The following is a description of a gene set: Mouse Gene Set: LIANG_HEMATOPOIESIS_STEM_CELL_NUMBER_SMALL_VS_HUGE_UP We mapped quantitative trait loci that accounted for the variation in hematopoietic stem cell (HSC) numbers between young adult C57BL/6 (B6) and DBA/2 (D2) mice. In reciprocal chromosome 3 congenic mice, introgressed D2 alleles increased HSC numbers owing to enhanced proliferation and self-renewal and reduced apoptosis, whereas B6 alleles had the opposite effects. Using oligonucleotide arrays, real-time PCR and protein blots, we identified latexin (Lxn), a gene whose differential transcription and expression was associated with the allelic differences. Expression was inversely correlated with the number of HSCs; therefore, ectopic expression of Lxn using a retroviral vector decreased stem cell population size. We identified clusters of SNPs upstream of the Lxn transcriptional start site, at least two of which are associated with potential binding sites for transcription factors regulating stem cells. Thus, promoter polymorphisms between the B6 and D2 alleles may affect Lxn gene expression and consequently influence the population size of hematopoietic stem cells. from publication Liang Y, Jansen M, Aronow B, Geiger H, Van Zant G (PMID 17220891) Genes up-regulated in LSK cells (bone marrow) as a function of a QTL for the size of hematopoietic stem cell (HSC) population: comparison of congenic D.B. Chr 3 (DB, small HSC population) vs parental D2 strain (huge HSC population). species: Mus musculus, and this is the list of marker genes: Pls3, Lyrm2, Tlcd4, Gsta4, Tpm4, Mat2b, Comt, Fhl2, Scamp1, Eif3b, Qdpr, Fcer1a (NCBI Gene Id 14125), Clcn3, Ccr5, Rxylt1, Pawr, Plscr2, Lxn, Zfp68, Gclm, Smim7, Chil3, Ube2d3, 1700017B05Rik, Dynlt2a1, Stx7, Gtf3a, Tfcp2l1 (NCBI Gene Id 98219), Agrn, Itfg1, S100a11, Gas2, Glb1l, Garin5b, Eif4e, Gpr137b-ps, Irf6, Slc35d1, Fads1, Gfi1b, Acadm, Aplp2